The following is a description of a gene set: The chemical reactions and pathways resulting in the breakdown of small molecules, any low molecular weight, monomeric, non-encoded molecule. species: Homo sapiens Human Gene Set: GOBP_SMALL_MOLECULE_CATABOLIC_PROCESS, and this is the list of marker genes: OAT, CYP1A1, ARG1, PGAM1, AKR1B10, MAPDA, ETFA, AKR1A1, BCKDHA, PNP, DLD, URAD, PEX13, BCL2L13, KYAT1, HAGH, SHMT1, PM20D2, SULT2A1, BLMH, ENO1, ETFB, CRYL1, SDS, LDHC, ALDH1L2, DCTD, PIPOX, MPI, GPD2, NUDT5, ADCY10, AGXT, GLB1L2, GALE, PCCB, ABCB11, APOE, GSTZ1, TKFC, CYP24A1, SORD, KYNU, THNSL2, SULT1A4, LONP2, PNKD, ADTRP, GK2, SLC25A44, ENSG00000293349, CARNMT1, HAO1, PGM1, CYP26A1, GLUD2, GCDH, FUT8, ABCD4, PLIN5, SCP2, ECHDC1, HK2, ACBD5 (acyl-CoA binding domain containing 5), CYP39A1, PPM1K, NQO2, MTHFS, CBS, ABHD3, ECHDC2, UPB1, ENTPD4, CYP4F3, CPT1A, BCAT2, NAALAD2 (N-acetylated alpha-linked acidic dipeptidase 2), ACADSB, GATD1, GPI, PFKL, GDA, IRS1, ACOT8, PGK1, PEX5, GNPDA2, CYP4F8, KMO, ACSS1, SULT1B1, ADHFE1, CSAD, SCARB1, GALM, HNMT, DPEP1, PGAM2, AKT2, HACL1, ACAA1, HIBADH, FUT7, HAL, LDHD, ARHGAP11B, PHYH, GCAT, PKM, ACADVL, PFKFB2, PARK7, AMT, HDC, UROC1, ILVBL (NCBI Gene Id 95885), DHDH, MCCC2 (NCBI Gene Id 64087), ACOX2, CYP2W1, CPT1B, CYP4F2, QDPR, CYP46A1, GLUL, AASDHPPT, UPP2, ACADM, CDADC1, CYP26B1, DPYD, HADH, NPL, TWIST1, AKR1C3, PEX7, IL4I1, MFSD2A, FUT9, ABCD3, ALDH3B2 (aldehyde dehydrogenase 3 family member B2), SULT1C4, AMDHD2, MCCC1, CDA, CROT, ATP2B4, ACOT4, GALT, ABCD2, SCARF1, GAD1, FUT2, ACOX3, PCK2, CDO1, ABAT, PFKP, PPARA, ESD, FOXK2, ABHD1, NAGK, CARNS1, CYP7A1, ALDH2, XDH, CBR3, APOBEC3C, FTCD, TKTL1, ACSF3, PPARD, IRS2, ADH5, XYLB, ACADL, GLS, GOT1, ACOX1, KYAT3, SDSL, EHHADH, GPT, SLC16A1, AADAT, NUDT1, CYP26C1, ECI1, GLS2, PON3, AICDA, SARDH, HADHB, FUT10, ADA2, TYSND1, FUT4, ALDOB, OXCT1, ENTPD7, CYP3A4, ENO2, NUDT7, ECH1, DAO, AMDHD1, ACAD10, RBKS, GSK3A, AFMID, ALDH6A1, DCXR, MIR21, GALK1, GLDC, TPI1, GK, BCKDK, HAAO, AKT1, OXCT2, ALDH4A1, ABCD1, FAH, GNPDA1, SLC27A4, FUT6, BCAT1, MTRR, HK3, FUT5, ASRGL1, PDXP, MCEE, HSD17B6, NUDT19, CPT2, SRD5A3, GLB1L, SLC25A17, ACMSD, PRODH, AKR1D1, NOS2, AASS, PCCA (NCBI Gene Id 5095), CYP4F11, HMGCLL1, HSD17B14, ALDH1B1, NOS1, ACSS2, LEP, LDHA, UPP1, PAH, FOXK1, GLB1L3, ACTN3, PON1, NTSR1, ACACB, FGF23 (fibroblast growth factor 23), GCK, PEX2, PCK1 (phosphoenolpyruvate carboxykinase 1), HPD, ACADS, GOT2, TIGAR, SLC16A3, DDAH1, FUT1 (fucosyltransferase 1 (H blood group)), MTLN, DPEP2, ALDH3B1, APOBEC3G, IDO1, SESN2, IDO2, TDO2, ETFBKMT, ADIPOQ, SCLY, CYP27B1, DECR2, DLST, LRP5, DECR1, SULT1A2, SULT1A3, MTAP, NUDT8, ECI2, MAT1A, DLAT, LPIN3, HK1, HYKK, HSD17B4, FAAH, SLC27A2, ECHS1, NOS3, TAT, ENSG00000274276, GLB1, QPRT, HSD17B10, ALDH8A1, MPST, DERA, IVD, GPT2, SULT1E1, ADA, GLUD1 (NCBI Gene Id 2746), BDH2, ACOT7, GCSH, CYP27A1, ACAA2, CYP4F12, GAD2, ACOXL, ETFDH, PRODH2, PFKM, LPIN1 (lipin 1), MIR210, CRAT, GK5, FMO1, MIOX, AGXT2, ENPP4, NUDT3, PLA2G15, CRYM, RIDA, LPIN2, AUH, GLYATL2, TST, BAD, ARG2, DDO, AMACR, TP53, HOGA1, OTC, MGAT1, SLC25A21, AIG1, HGD, BCKDHB, ENO3, ACAD11, ACAT1, ABHD2, ADH4, CYP4A11 (NCBI Gene Id 1579), MLYCD, ALDH5A1 (aldehyde dehydrogenase 5 family member A1), HIBCH, HADHA, ACAD8, SULT1A1, GLYCTK, DBT, PGK2, ALDH1L1, SNX17, RENBP, HMGCL, MCAT